Given this list of marker genes CFL1, PARVA, PARVG, PARVB, MARK2, here is a description of the gene set: Human Gene Set: GOBP_ESTABLISHMENT_OR_MAINTENANCE_OF_CELL_POLARITY_REGULATING_CELL_SHAPE species: Homo sapiens Any cellular process that results in the specification, formation or maintenance of a polarized intracellular organization or cell growth patterns that regulate the shape of a cell.